Given this list of marker genes TRIM6, MNDA, CALM1, IFNAR1, UBE2G2, HCN1, PYHIN1, GPR146, TREX1 (three prime repair exonuclease 1), CAMK2A, STING1, IKBKE, IFI16, IFITM1, IFITM2, OAS1, NDUFA13, BST2, IFITM3, IRF1, PYDC5, IFNB1, DDX41, STAT1, IRGM, CDC34, PLSCR1, PNPT1, ACOD1, UBE2K, AIM2, CAPN2, SHFL, TLR3, XAF1, HTRA2, IFNAR2, here is a description of the gene set: studied in species Homo sapiens Any process that results in a change in state or activity of a cell or an organism (in terms of movement, secretion, enzyme production, gene expression, etc.) as a result of an interferon-beta stimulus. Interferon-beta is a type I interferon. Human Gene Set: GOBP_RESPONSE_TO_INTERFERON_BETA